Given this list of marker genes PCNA, POLB (NCBI Gene Id 5423), POLE2, TDG (NCBI Gene Id 93091), POLE, POLD2, RPA3, MPG, OGG1, MBD4, RFC2, PARP2, POLD3, NTHL1, LIG3 (DNA ligase 3), RFC1, POLD4, POLE4, PNKP, RFC3, RPA2, FEN1, POLE3, NEIL1, UNG, LIG1, SMUG1, NEIL2, PARG, POLD1, RFC4, RPA1, PARP1, MUTYH, ADPRS, APEX1, XRCC1, RFC5, here is a description of the gene set: species: Homo sapiens part of: Base Excision Repair Reactome Pathway: Resolution of Abasic Sites (AP sites) Resolution of AP sites can occur through the single nucleotide replacement pathway or through the multiple nucleotide patch replacement pathway, also known as the long-patch base excision repair (BER). Except for the APEX1-independent resolution of AP sites via single nucleotide base excision repair mediated by NEIL1 or NEIL2, single nucleotide and multiple-nucleotide patch replacement pathways are both initiated by APEX1-mediated displacement of DNA glycosylases and cleavage of the damaged DNA strand by APEX1 immediately 5' to the AP site. The BER proceeds via the single nucleotide replacement when the AP (apurinic/apyrimidinic) deoxyribose residue at the 5' end of the APEX1-created single strand break (SSB) (5'dRP) can be removed by the 5'-exonuclease activity of DNA polymerase beta (POLB). POLB fills the created single nucleotide gap by adding a nucleotide complementary to the undamaged DNA strand to the 3' end of the SSB. The SSB is subsequently ligated by DNA ligase III (LIG3) which, in complex with XRCC1, is recruited to the BER site by an XRCC1-mediated interaction with POLB. BER proceeds via the multiple-nucleotide patch replacement pathway when the AP residue at the 5' end of the APEX1-created SSB undergoes oxidation-related damage (5'ddRP) and cannot be cleaved by POLB. Long-patch BER can be completed by POLB-mediated DNA strand displacement synthesis in the presence of PARP1 or PARP2, FEN1 and DNA ligase I (LIG1). When the PCNA-containing replication complex is available, as is the case with cells in S-phase of the cell cycle, DNA strand displacement synthesis is catalyzed by DNA polymerase delta (POLD) or DNA polymerase epsilon (POLE) complexes, in the presence of PCNA, RPA, RFC, APEX1, FEN1 and LIG1. It is likely that the 9-1-1 repair complex composed of HUS1, RAD1 and RAD9 interacts with and coordinates components of BER, but the exact mechanism and timing have not been elucidated.